The following is a description of a gene set: from publication Schaefer CF, Anthony K, Krupa S, Buchoff J, Day M, Hannay T, Buetow KH (PMID 18832364) species: Homo sapiens Signaling events mediated by HDAC Class III Human Gene Set: PID_HDAC_CLASSIII_PATHWAY, and this is the list of marker genes: SIRT3, TUBA1B, SIRT2, CREBBP, FOXO4, PPARGC1A, ACSS2, SIRT1, MYOD1, XRCC6, H1-4, HDAC4, EP300, TP53, MEF2D, CDKN1A, TUBB2A, FOXO3, FOXO1, KAT2B, BAX, ACSS1, HOXA10, SIRT7, H4C9, FHL2